Given this list of marker genes Ufc1, Cdk5rap3, Ufl1, Ufm1, Ddrgk1, Uba5, here is a description of the gene set: Covalent attachment of the ubiquitin-like protein UFM1 to another protein. Mouse Gene Set: GOBP_PROTEIN_UFMYLATION species: Mus musculus